The following is a description of a gene set: Mouse Gene Set: GOBP_NEGATIVE_REGULATION_OF_CELLULAR_RESPONSE_TO_VASCULAR_ENDOTHELIAL_GROWTH_FACTOR_STIMULUS Any process that stops, prevents or reduces the frequency, rate or extent of cellular response to vascular endothelial growth factor stimulus. species: Mus musculus, and this is the list of marker genes: Pik3cb, Spry2, Hrg, Il12b, Adamts12, Sema6a, Adgra2, Il12a, Dab2ip, Xdh, Atp2b4, Cadm4, Dcn, Emilin1